Given this list of marker genes XIAP, APAF1, CYCS, DIABLO, CASP3, CASP7, CASP9, here is a description of the gene set: Reactome Pathway: SMAC (DIABLO) binds to IAPs part of: SMAC, XIAP-regulated apoptotic response Second mitochondria‑derived activator of caspases protein (SMAC, also known as direct IAP binding protein with low pI or DIABLO) in its dimeric form interacts and antagonizes X‑linked inhibitor of apoptosis protein (XIAP) by concurrently targeting both BIR2 and BIR3 domains of XIAP (Chai J et al. 2000; Liu Z et sl. 2000; Burke SP & Smith JB 2010). XIAP inhibits apoptosis by binding to and inhibiting the effectors caspase‑3 and ‑7 and an initiator caspase‑9 (Deveraux QL et al. 1997; Paulsen M et al. 2008). During apoptosis, SMAC (DIABLO) is released from the mitochondria (Du C et al. 2000). In the cytosol, SMAC binds to XIAP displacing it from caspase:XIAP complexes liberating the active caspases (Wu G et al. 2000; Abhari BA & Davoodi J 2008). studied in species Homo sapiens